The following is a description of a gene set: Human Gene Set: GOBP_DETECTION_OF_TEMPERATURE_STIMULUS_INVOLVED_IN_THERMOCEPTION studied in species Homo sapiens The series of events in which a temperature stimulus is received and converted into a molecular signal as part of thermoception., and this is the list of marker genes: GRIK2, RHO, TRPV1, OPN4, WDR47 (NCBI Gene Id 22911)